The following is a description of a gene set: Human Gene Set: MURARO_PANCREAS_DELTA_CELL species: Homo sapiens from publication Muraro MJ, Dharmadhikari G, Grün D, Groen N, Dielen T, Jansen E, van Gurp L, Engelse MA, Carlotti F, de Koning EJ, van Oudenaarden A (PMID 27693023), and this is the list of marker genes: UNC80 (unc-80 homolog, NALCN channel complex subunit), MBNL2, FXYD6, KCNT2, LRCH2, MAP2, BAMBI, DNAJB9, PNMA1, SLC17A6, RIPPLY3, FGF12, CXXC4, ZKSCAN1, ACVR1B, AMPH, STAU2, FANCF, IDS, SAMD5, CAMK2B, CELF4, LMO2, EPHX2, FAM167A, SNAP25, IER2, FOXP2, PRKACB (NCBI Gene Id 5567), RUNX1T1, INPP5F, EDN3 (NCBI Gene Id 1908), DUSP6, PRSS23, UCP2, NPHP4, FFAR4, LCORL, FRZB, DNAJC12, TPPP3, PARVB, SESN3, PIPOX, NBEA, HADH, PCSK1, ITM2C, PAK3, TENM2, PAM, PHGR1, ABI3BP, UBE2QL1 (ubiquitin conjugating enzyme E2 QL1), ST8SIA4, GABRA1, QDPR, MAP1B, RUNDC3A, ACSL1 (NCBI Gene Id 91249), PLXNA2, ARL4D, VWA5A, SLC38A1, PKDCC, MAGEL2, SLC2A13, KRT10, MCC, ENSG00000286190, ELAVL4, TCEAL5, FBXL16, VAT1L, KCNH2, SLC7A5P2, KCTD8, BEX4, BAALC, NCAM1, ETV1, CBLN4, BEX1, EGR1, ERBB4, SCRN1, KCNB2, MS4A8, ICA1L, ZMAT1, SORL1, RUFY3, STXBP5L, SETBP1, NECTIN3, RHOBTB3, BHLHE41, GCH1, CADM1, FOS (Fos proto-oncogene, AP-1 transcription factor subunit), LPIN1 (NCBI Gene Id 23175), SST, TMEM200A, CD9, HTATSF1, LRFN5, PLEKHB1, KCNIP1, TTC3, OXCT1, CEP41, RADX, HAP1, HEPACAM2, SLC6A17, THSD7A, FHOD3, CDKN2A, LEPR, SSTR1, TCEAL3, DIRAS3, BTG3, MEST, PROX1, PEG10, PDE2A, SEC11C, FGF14, CALB1, CASR, PNRC2, GABRB3, TSHZ2, POU3F1, WHRN, TBC1D24, SYNE2, ST3GAL1, MAP6, FTO, GABRG2, CALCB, UNC5B, TPD52, CABP7, PCP4, PBX3, PKIB, RGS2, DYNC2H1, HPN, ISL1-DT, IRS2, ARFGEF3, HHEX, PON3, ADGRV1 (adhesion G protein-coupled receptor V1), EEIG1 (estrogen-induced osteoclastogenesis regulator 1), HSPA6, CYFIP2 (NCBI Gene Id 81032), JAM3, ABCC5, BTG2, PREPL, CDK14, RCAN3, DPYSL3 (NCBI Gene Id 54406), BEX2, DNAJC6, MIR7-3HG, RBP4, PCK1, ST8SIA3, DHRS2, PDLIM4, LINC00261, UCHL1, CPE, CADPS, GAL, TLE2, NSG1, SILC1, ABCC9, BCHE, EYS, PNMA2, PEG3 (NCBI Gene Id 5178), SYT4, INSM1, NDRG4, AQP3, PCLO, HMGCLL1, AHI1, PNMA8A, DUSP26, LONRF2, GHSR, EXOC6, SYT1, PPP4R4, TANC2, AMIGO2, MDFIC, KCNJ2, SERTAD4BP, NUDT9, PSIP1, TCEAL6, ISL1, MAP9, CHN2, ANK3, NUAK1, PDZRN3, F5, PCSK1N, NOL4, HMOX1, KCNJ8, HID1, TENM3, ADGRL2, TCEAL2, SLC4A8, GAD2, MRAP2, AKAP12, CDHR3, ERICH3, TMOD1, TMEM132D, PRG4, LRRC42, MTURN, EHF, RAB3D, C14orf132, SLC7A5, MLPH, ABHD16A, GPAT4, APOBEC2, NAP1L3, PJA2, PTPRN, CREM, PAIP2B